The following is a description of a gene set: species: Homo sapiens Genes having at least one occurrence of the motif DGATADGAHWAGATA in the regions spanning 4 kb centered on their transcription starting sites. This matches the EVI1 transcription factor binding site V$EVI1_04 (v7.4 TRANSFAC). Human Gene Set: EVI1_04, and this is the list of marker genes: EXT1, SSX5, SP3, RELA, GPR107, NEUROD6, PDGFC, SEMA6A, HAS2, MAX, CHD6, LZTS2, PDE4D, UTP18, NHLH2, ZFAND6, PRL, ACKR1, PTGR3, NEDD4, HOXA2, OPCML, ATOH1, SLC40A1, BMPR2, CHCHD7, MYO3B, LOX, HOXC4, PLAG1, SOX5, CYP17A1, CRYAB, MIR137HG, ZIC4, LUZP1, EIF5, TCP11L2 (t-complex 11 like 2), EBF1, HIPK3, PLPP3, SERTAD4, RERE, PPARGC1A, SLITRK6, MYH4, KLF7, NCBP3, ONECUT2, RAPGEFL1, SALL2, RPS6KB1, ANP32D, RALYL, KCNJ13, CRH, BCL11B (NCBI Gene Id 64919), HSPB2, IPO4, LINC00525, LRRTM1, H3-3B, B3GALNT2, DENND2B (DENN domain containing 2B), ZFX, NRXN3, NFATC4, GRIA3, NEK10, UBR5, HTR3B, POGZ, MTUS1, MGAT4C, SLC17A6, IL25, ZBED5, MID1, MYH2, PEPD, ISL1, TLCD4, ANKRA2, HOXD10, APOOL, P2RY12, MORC4, ACTC1, CHRDL1, IL1RAPL1, CASQ2, NR2F6, EMX2, ZIC1, PTCH2, PABIR1, CER1, HNRNPA0, SREK1, GSX1, CABLES1, PTCH1, SRSF1, FGF12, EYA1, ELAVL4, ASCL4, PRKAG1, NPNT, LMO4, C6orf62, TWIST1, SAMD11, NR2F1, HHATL, MRPS23, CALHM4, CASK, ANKRD46, LRR1, SEPHS2, SCML1, MCTS1, NEUROD2, EDN1, ITGA8, NR2F2 (NCBI Gene Id 7026), NMNAT3, MIR9-1HG, SLC13A1, FAM50A, CSNK1E, CLASP1, TYRO3, ATP5MC2 (NCBI Gene Id 517), KIRREL3-AS3, LDB2, GRM1, TMEM88, CYP46A1, HOXB3, PTGFR, JPT2, STOML2, LINC00314, CACNA1C, RAI1, SMPX, COX8A, TPM1, NIM1K, MAP2K5, GLRA2, CPNE1, ADAMTS6, ENTR1, CDKN2C, PDZRN4, CTNNA3, PHOX2B, STC1, MBNL1, GDI1, COL13A1, HOXC11, ZFHX3, SLC4A4, RAB11FIP1, FUT11, FGF13, RBM39 (RNA binding motif protein 39), DNAJC5B, NT5C1B, PTCHD4, LRP1, BDNF, FOXP2, BEND4, KLF5, RTKN2, GARRE1, HOXB7, PPOX, OTP, RORB, KIZ, LMO3, TGFB2, DNAJA4, HPSE2, TNFRSF8, DLG2, NOTCH2, MEIS2, DDX17, DMD, GRIK3, DBNDD2, TOB1, IL2RG, RARG, GJB1, AP3M2, KIRREL3, ARHGAP6, NECAP1, EHF, WT1-AS, CHAC1, CSMD3, BUB3, PRMT9, NRAS, POU4F2, NOTCH2NLA, RHBDL3, PRDM1, LUC7L3, RAB1A, TNFSF4, ACACA, PCDHA5, ARRDC3, SLITRK2, WNT2B, IKZF2, RELCH, VAMP3, LRRTM3, CD180, HOXC6, HOXD4, NRG1, SOBP, DHRS3, RCOR1, MYH11, FZD2, BCL11A, NCAM2, RHOB